Given this list of marker genes ITGB1, C1QL1, CX3CL1, C1QA, TREM2, C1QB, PLXNC1, CX3CR1, C1QC, C3, DKK1, SARM1, ITGAM, VANGL2, ADGRB3, EPHA4, KCNK13, NGEF, here is a description of the gene set: Human Gene Set: GOBP_SYNAPSE_PRUNING A cellular process that results in the controlled breakdown of synapse. After it starts the process is continuous until the synapse has disappeared. species: Homo sapiens